The following is a description of a gene set: Shoulder dislocation Human Gene Set: HP_SHOULDER_DISLOCATION studied in species Homo sapiens A displacement or misalignment of the humerus with respect to the other bones of the should joint. Note that a subluxation is a partial dislocation., and this is the list of marker genes: AEBP1, NEDD4L, ERMARD, B3GAT3, CHST3, COL5A2, NGLY1, COL1A1, LMNA, COL5A1, TBX5 (T-box transcription factor 5), ARF1, FLNA, TMTC3, MAP1B, COL1A2, SALL4, ARFGEF2